Given this list of marker genes GNAI3, TMEM107, INTU, KIF7, TCTN3, NEK1, TMEM216, EDN1, PDE6D, KIAA0753, OFD1, MAN2C1, DDX59 (NCBI Gene Id 83479), C2CD3, CPLANE1, PLCB4, TOPORS, DYNC2H1, KIAA0586, TMEM231, FAM149B1, CEP120, WDPCP, here is a description of the gene set: Human Gene Set: HP_HAMARTOMA_OF_TONGUE A benign (noncancerous) tumorlike malformation made up of an abnormal mixture of cells and tissues that originates in the tongue. species: Homo sapiens Hamartoma of tongue